Given this list of marker genes PRKCA (protein kinase C alpha), N4BP1, H2BC1, CERK, PSMB9, ARL5C, DCTD, EXOC1, ADAMTS6, HIP1, TSPAN2, PGPEP1L, CTDSPL (NCBI Gene Id 10217), PLXNA1, ARRDC4, PICALM (phosphatidylinositol binding clathrin assembly protein, NCBI Gene Id 8301), ARID5B, KNTC1, NFIL3 (nuclear factor, interleukin 3 regulated), SCPEP1, CPD, NT5E, TTC39B (tetratricopeptide repeat domain 39B), PLXNC1, SLMAP, PAFAH1B3, RALGDS, EPCAM, GNG2, PPP2CA, BATF, KIT, RNPEP, CAMSAP1, CD81, TMEM167A, GYG1, NFKBIE, MCOLN3, CD83, FARP1, FHL2, AP2S1, SMAD3, MYADM, CNPY2, SPTLC2, H2AZ1, ANKRD17, IMMP2L (inner mitochondrial membrane peptidase subunit 2), TRIB1, RHOH, ZDHHC21, PTPN13, YIPF1, RPAP3, HMGN3, ALAD, MAP3K5, GIMAP7, TBC1D31, RNF216, ZC2HC1A, DUSP1, AHCYL1, S100A11, CENPA, XIAP (NCBI Gene Id 8257), H4C3, NF2, MBNL3, FGR, BTBD16, FOXO3, RAD51B, GBP3, TJP2, NOL10, SYNGR2, SERINC5, MAD2L1, PLIN2, AHCYL2, PTGER4, RAB27A, CD44, HSPA4L, EBP, DONSON, CST3, GPRASP3, CYFIP1, EZH2, APLP2, CIAO1, ABHD4 (NCBI Gene Id 63874), NIPAL1, EFCAB12, BUB1B, SYT11, TBC1D30, VPS4B, STAT5A, PSME4, CLSPN (claspin), SCLY, FOSB, GRN, FAM234A, TMEM65, LXN, KIF14, P2RX7, PEX11A, B4GALNT4, AURKA (aurora kinase A), VPS54, E2F2 (NCBI Gene Id 1870), GPR55, RLN3, ERMP1, CIBAR1, ASXL1, TRPS1, STRN, RDH12, GLIPR2, PLD1, ATP6V1A, TWSG1, PCNP, BAIAP3, LPIN2 (lipin 2), UBE2F, IFT22, HASPIN, KNL1, NSMAF, MCTP1, GEMIN2, IRF5, SSX2IP (SSX family member 2 interacting protein), SOAT1, CTSA, STIM2, NDUFA4, TRAF2, ASB2, TBRG1, LPXN, MAP3K8, GAS2L3, SESN1, ADAM8, MVD, CST7, RAB43, ACTB (NCBI Gene Id 60), SNX18, ZFP41, UBASH3B, ZNF670, LARP1B, OXR1, IL1RL1, TNFAIP8, UNC119B, CCR9, HUWE1, GPLD1, TMEM154, RASGEF1B, VAV2, CNIH4, PGLYRP1, here is a description of the gene set: In this study we compared the effects of IL-2, IL-15, and IL-21 on the gene expression, activation of cell signaling pathways, and functional properties of cells derived from the CD4+ cutaneous T-cell lymphoma (CTCL). Whereas both IL-2 and IL-15 that signal through receptors that share the common gamma chain and the beta chain modulated the expression of >genes, IL-21 that signals via the receptor also containing gamma chain up-regulated <genes. All three cytokines induced tyrosine phosphorylation of Jak1 and Jak3. However, only IL-2 and IL-15 strongly activated STAT5, PI3K/Akt, and MEK/ERK signaling pathways. In contrast, IL-21 selectively activated STAT3. Whereas all three cytokines protected CTCL cells from apoptosis, only IL-2 and IL-15 promoted their proliferation. The effects of the cytokine stimulation were Jak3- and Jak1-kinase dependent. These findings document the vastly different impact of IL-2 and IL-15 vs. IL-21 on malignant CD4+ T cells. They also suggest two novel therapeutic approaches to CTCL and, possibly, other CD4+ T cell lymphomas: inhibition of the Jak1/Jak3 kinase complex and, given the known strong immunostimulatory properties of IL-21 on CD8+ T, NK, and B cells, application of this cytokine to boost an immune response against malignant CD4+ T cells. from publication Marzec M, Halasa K, Kasprzycka M, Wysocka M, Liu X, Tobias JW, Baldwin D, Zhang Q, Odum N, Rook AH, Wasik MA (PMID 18281483) Genes up-regulated in Sez-2 cells (T cell lymphoma): IL2 versus IL21. Human Gene Set: GSE8685_IL2_ACT_IL2_STARVED_VS_IL21_ACT_IL2_STARVED_CD4_TCELL_UP studied in species Homo sapiens